The following is a description of a gene set: from publication Wang S, Zhan M, Yin J, Abraham JM, Mori Y, Sato F, Xu Y, Olaru A, Berki AT, Li H, Schulmann K, Kan T, Hamilton JP, Paun B, Yu MM, Jin Z, Cheng Y, Ito T, Mantzur C, Greenwald BD, Meltzer SJ (PMID 16449976) To investigate the relationship between Barrett's esophagus (BE) and esophageal adenocarcinoma (EAC), we determined gene expression profiles of discrete pathological stages of esophageal neoplasia using a sequence-verified human cDNA microarray. Fifty one RNAs, comprising 24 normal esophagi (NE), 18 BEs, and nine EACs were hybridized to cDNA microarrays. Five statistical analyses were used for the data analysis. Genes showing significantly different expression levels among the three sample groups were identified. Genes were grouped into functional categories based on the Gene Ontology Consortium. Surprisingly, the expression pattern of BE was significantly more similar to EAC than to NE, notwithstanding the known histopathologic differences between BE and EAC. The pattern of NE was clearly distinct from that of EAC. Thirty-six genes were the most differentially modulated, according to these microarray data, in BE-associated neoplastic progression. Twelve genes were significantly differentially expressed in cancer-associated BE's plus EAC (as a single combined tissue group) vs noncancer-associated BE's. These genes represent potential biomarkers to diagnose EAC at its early stages. Our results demonstrate that molecular events at the transcriptional level in BE are remarkably similar to BE's-associated adenocarcinoma of the esophagus. This finding alarmingly implies that BE is biologically closer to cancer than to normal esophagus, and that the cancer risk of BE is perhaps higher than we had imagined. These findings suggest that changes modulated at the molecular biologic level supervene earlier than histologic changes, and that BE is an early intermediate stage in the process of EAC. Candidate progression biomarkers up-regulated in transition from non-tumor-risk associated to tumor-risk associated Barrett's esophagus and then to esophageal adenocarcinoma (EAC). Human Gene Set: WANG_ESOPHAGUS_CANCER_PROGRESSION_UP studied in species Homo sapiens, and this is the list of marker genes: MMP7, DUSP2, MYADM, TNFRSF12A, HSPE1, CXCL3, PLAUR, SRGN, P3H4